The following is a description of a gene set: species: Homo sapiens HSC Human Gene Set: HE_LIM_SUN_FETAL_LUNG_C2_HSC_CELL from publication He P, Lim K, Sun D, Pett JP, Jeng Q, Polanski K, Dong Z, Bolt L, Richardson L, Mamanova L, Dabrowska M, Wilbrey-Clark A, Madissoon E, Tuong ZK, Dann E, Suo C, Goh I, Yoshida M, Nikolić MZ, Janes SM, He X, Barker RA, Teichmann SA, Marioni JC, Meyer KB, Rawlins EL (PMID 36493756), and this is the list of marker genes: ANKRD27, RIOX1 (NCBI Gene Id 79697), TBC1D31, METTL3, BOLA2-SMG1P6, LRRC70, MYLK-AS1, PKD2, TUBB4A, NREP (neuronal regeneration related protein), IL12RB2, AP1G2, KCNQ1OT1, MRPL48, CEP95, ZNF227, ZFP14, TFAP4, DYNC2LI1, LRRC23, HOPX, STARD10, TMEM68, STMN3, KPTN, WDR18, STK26, ZNF329, MAP3K7, TMEM35B, BSPRY, TRMT61B, RECQL5, ARMH1, IPO13, ZNF346, ZNF496, SQLE, ARMC6, ZNF37A, IGSF10, CNNM2, LRRC8A, ZNF420, SACS, PSMD10 (NCBI Gene Id 5716), ZNF429 (zinc finger protein 429), ZEB1, TMEM254, BCR (NCBI Gene Id 729775), POT1, DNAJC18 (DnaJ heat shock protein family (Hsp40) member C18), DDHD2, TTC4, NXPE3, RBM28, C18orf21, MLH3, DSG2, HOXB4, UNG, GLE1, ANKLE2, POLR2C, RABL2A, PRIM2, TIMM8A, TNFSF4, TRMT10C, PUS7L, GNPAT, CCAR2, GEMIN4, PKIG, OXLD1 (oxidoreductase like domain containing 1), PMS2, FBXW9, RGL4, AK6, KATNB1, MIX23, ARID5B, ZFAND2B, ING3, CERCAM, MOAP1, PRPF39, C9orf43, ARL2, USP47, SLC9B2, SVOPL, PCMTD2, ZNF574, PRKACB, NBPF1, ZNF708, ING5 (NCBI Gene Id 84289), SRP68, PHF19, SMIM8, MMUT (methylmalonyl-CoA mutase), SSBP2, TMTC4 (transmembrane O-mannosyltransferase targeting cadherins 4), TMEM63A, CAVIN1, PLA2G6, ACP6, HPS4, C1orf131, CPLANE1, PXMP2, ACTR6, WDR3, XAF1, TAPT1, RNF214, CUTC, RNF24, CNTROB, TGIF2, PTAR1, EAF2, FASTKD1, SLC27A5, TBL2, INTS8, SARS2, IPO5, TARS3, ANTXR2, MTRFR, SMYD3 (NCBI Gene Id 81838), PROM1, EIF1AY, MRPS2, CHRFAM7A, GAPT, PRR3, TMEM263, DTWD1, HIBADH, CASD1, GLI4, ECSIT, STK38, EFHC1 (NCBI Gene Id 94915), PGRMC1, MZF1, SCFD2 (sec1 family domain containing 2), CD79B, P2RX1, MMAB, PCNX4, MIR497HG, KRBOX4 (KRAB box domain containing 4), ZNF451, CERS5, ZCCHC7, PGAP2, ADK, TFPI, KCNQ5, SLC35B3, ULK4, POLD2, C12orf43, CCDC34 (NCBI Gene Id 91057), F2R, AUTS2, ABHD17B, SYTL1, ARMC8, DKC1, CFAP119, RAMP1, AGBL5, COQ4, FANCM (NCBI Gene Id 57697), CEP20, HECTD3, SLC39A3, PEX2, CIBAR1, C1RL, NSUN3, ZNF618, ZDHHC21, PRMT6, MRPL46, DDX19A, NMRAL1, TP53I3, MED20, GUF1, CENPC, UBIAD1, TOPORS, ABRAXAS2, ZC4H2, ZFP90, DYRK1B, ENTPD1-AS1, MOB2, ZNF680, KRBA2, SETMAR, ME3, RNF31, BICRAL, C16orf87, PIGM, UBL7-DT, UBFD1, DVL2, ATP8B4, SEC22C, STAP1, DLG1, ZER1, TRIM13, KIAA1586, SULT1C4, NUP35, DCAF13, GOT2, ZNF830, NBPF11, KAT6B, PAXIP1-AS2, AP3M1, PIBF1, ARHGAP22, PALS1, LRRC8B, CIAO3, ZC3H8, GORAB, ERGIC1, KANSL3, MTM1, ZW10, LINC00667, PRXL2A, PBXIP1, TGFBRAP1 (NCBI Gene Id 9392), LINC01023, MAD2L1, ITFG2-AS1 (NCBI Gene Id 647957), CASC15, OXCT1, ZFPL1, ZFP64, ZNF69, LINC01003, WDR12, ARL13B, POLR2M, EBPL, ZNF610 (NCBI Gene Id 162963), DUSP28, MYO9A, SCCPDH, SCAMP1-AS1, ADPRM, GATB, FARSB, KRR1, TIPIN, UHRF2, B3GNTL1, EXOG, ZNF506, HACD3, SAAL1, RBAK, ZNF737, MIEF1, RAB30-DT, SPINK2, IGSF8, GPANK1, ZC3HC1, MIR181A1HG, ZMYND8, TGDS, STRBP, LLPH, TEFM (transcription elongation factor, mitochondrial), DNAJC9, CCDC97, ALDH6A1, CYYR1, HNRNPA1L3, ZBTB44, FAM86C1P, PABIR2, UNC45A, HIC2, UPF3B, PIGV, COL24A1, ZFAND1, NTHL1 (NCBI Gene Id 4913), FUT8, FKBP7, GNG11, SRPK1, DOLPP1, MOV10, ZNF254, GFM2, WDR59, ZNF576, MTHFD2L, ZBED5, ZBTB8A, CD82, HELLS, HEATR1, AHDC1, PTCD3, KIZ, SRD5A3 (NCBI Gene Id 79644), ALKBH4, MEG3, ING4, SMARCAD1, TMEM184C, GFM1, MAP7D3, PPFIBP1, CEP85, TARBP1, PRELID2, LDAH, PDCD4-AS1, UHRF1, ABHD10, P2RY8, R3HDM1, METTL15, CTSF, ZNF260, LANCL1, TAMM41, EIF2D, REXO5, RAD17, BOLA1, ITFG2, EXOSC3, IGF1R, ANKRD46, ACAP1, DYNLT5, C19orf48P, LRP5L, INTS13, FHIT, BLMH, SPATS2, ARHGEF3, NPR3, TCEAL9, IFT122 (NCBI Gene Id 55764), ICA1, ZNF426, SMIM1, ANKRD36C, ANKRD26, RIDA, EARS2, ZSCAN2, ACY1, GTF3C3, RFX5, TRBC2, UBA5, DPY19L3, LRRFIP2, HOXA10, RUVBL2, SCOC, COX11, IFRD2, ATP6V0E2 (NCBI Gene Id 155066), GRWD1, BLZF1, PBX1, MAPK8, ATP23, NEDD4, PITPNA-AS1, ZNF677, ARL16, UBR5-DT, ALDH1A1, BCL2, FAM161A, OARD1, PIGU, RPP38 (ribonuclease P/MRP subunit p38), SMARCD1 (SWI/SNF related, matrix associated, actin dependent regulator of chromatin, subfamily d, member 1), PARP6, DPF2, NUTM2B-AS1, NKAPD1, HMGB3, ZNF410, JMJD4, ATXN7L1, CDCA7L, NT5C3B, SLC44A2, ZCCHC9, FHL1, PDRG1 (p53 and DNA damage regulated 1), EFL1, RAD50, MAN1B1, ALG6 (ALG6 alpha-1,3-glucosyltransferase), ZNF253, ZNF85, AGPAT4, TBCK, KLHL7 (kelch like family member 7), TRIM58, ZBTB20, ZC3H6 (NCBI Gene Id 376940), RAVER1, ARL15, TARBP2, MYCN, ODF2L, RCBTB1, NUDT11, MPI, CCNT2, PRH1, PHTF1, MAP1A, RBM48, BAMBI, ST3GAL3, SLC25A20, WASF1, PRKCQ, NNT-AS1, XXYLT1, PITPNB, GPSM2, DYNC2I1, WDR5, CXXC5, SPART, KCTD18, MRPS30, KDM1A, NQO1, CCDC171, MSH2, ANKRD28, ESAM, SMC2, RCC1, EMID1, CKB, TMEM182, ZNF875, TASP1, CSTPP1, TBCCD1, MTHFD1, KDM5B, ACYP1, NBAS, SPATA7, CCDC14 (coiled-coil domain containing 14), TXNL4B, PRMT5, PHF6, ZNF766, CDK2, MPL, SLC35E3, SCAMP1, NDUFAF7, FAM30A, DTX3, TMCC1-DT, TPGS2, CASP2, RHBDD3, MDC1 (mediator of DNA damage checkpoint 1), CD38, NME1, CCDC28B, PILRB, C15orf40, IKZF2, VAMP5, NIT2, PIGP, GGH, ZDHHC9, TOR1B, GFER, KRBOX5, MYB, HDAC7, PRKAR1B, TRAPPC2, SCML4, LINC00539, INTS9, LRBA, RBM4 (NCBI Gene Id 5936), MSMO1, EXOC6, SUPT20H, SGF29, IGFBP7, ASH1L-AS1, NCBP2, CLDN10, NAPA-AS1 (NAPA antisense RNA 1), POLR3F, GSE1, TMEM106B, ASH2L, SPIDR, GBP4, CHD1L, ANKRD36B, SLF1, HSPA13, CAND1, SYNGR1, MRPL19, INKA1, IARS1, GFI1B, TSN, CBFA2T3, UBL4A, CASP7, ASB9, NUP37, TMEM101, STN1, NT5C2, TRMT61A, SEPTIN11, MKS1, THG1L, QTRT1, DCAF16 (DDB1 and CUL4 associated factor 16), PIM1, GUCY1A1, ALG9, ZNF606, ABCB1, CXXC1, KLHL23, PRMT3, LPIN1, TMEM177, PDE7A, LAS1L, USP21, ST3GAL4, SNHG10, ERV3-1, PAPSS1, ZNF561, RRP9, LMF1, EIF3J-DT, BTN3A1, RWDD3, LRRC41 (NCBI Gene Id 89995), TSEN54, ZBTB16, JUP, ATAD1, ZNF521, CLCN3, NOLC1, C21orf58, OCIAD2, TTLL12, ZNF226, LTBP4, ZNF302, TBP, NUP155, WWOX, KIT, ZSCAN9 (zinc finger and SCAN domain containing 9), WDR54, CCDC18, TRAM2, ACTL6A, RRAGB, IMMP1L, GOLGA8B, SCML2, CCDC125, DMAC2, GMDS-DT, MEF2C-AS1, TYW3, TEX10, UBE2T, STEEP1, SIRT5, SEH1L, DUSP11, DUSP12, IQCB1, NSUN4, RNF125, ATP2C1, SETD4, SMURF2, TRAFD1, WFDC1, LYRM1, MYC, HACD1, NFATC1, RCL1, TTC27 (NCBI Gene Id 55622), IPO11, CRY1, SLC25A26, MCM3, ZNF493, GTF3C5, TAF8, HOXA7, LDAF1, DPH1, SYNE1, ZNF131, MAGED1, B3GNT2, RAC3, CDCA4, ADNP, POLR3E, LRP5, HDGFL3, ZNF771, TOP1MT, RFX3, NFRKB, CD320, MAP9, WDR46, DYTN, MZB1, ABLIM1, PTTG1, ACSM3, FAM76B, PELI2, INTS4, ROBO3, HTRA2, TMIGD2, TMCO3, TSPAN2, ACCS, HACL1, EXOSC8, MKRN2 (NCBI Gene Id 29073), VIPAS39, CHST14, ZNF639, MATK, GOLPH3L, ZNF512, ABCC1, LETMD1, EML2, ATP6V0A2, RIOK2, TMEM41A, C16orf54, PLCXD1, DPPA4, CABIN1, RSPRY1, ZNF33B, CERS6, BICD1, MAP4K2, INTS7, RBM7, SLC25A17, EXOSC7, ZNF134, H2AC25, PEX14, PIP5K1B, STRADA, DCTD, FAM216A, NAA35, ZNF268, G2E3, MRPS27, IFT57, RPAP1, HENMT1, XKR8, HIBCH, NIPAL3, NR2C1, UQCC6, STIM1, VAT1, PEX5, TTC19, ARL4D (NCBI Gene Id 379), PLAGL1, H2AC14, NAPEPLD, GFOD2, TNIK, ALDH1B1, HOMEZ, TP53I13, ECI2, NCBP2AS2, DIMT1 (NCBI Gene Id 27292), UBXN7, ORC2, METTL8 (methyltransferase 8, tRNA N3-cytidine), CD34, CASP8, GPATCH4, SLC35E2A, TTC32, INPP4B, COPG2, GALNT7, NAP1L3, PPP1R37, TMEM185B, PAPOLG, RPGR, KCNN4, BDH2, MEN1, CALCOCO1, DTD1, UBA7, EPM2AIP1, MTX2, PTP4A3, MACO1, MPHOSPH10, CD7, GSTM3, CDK17, PDCD11, ACSS1, HDAC8, KEAP1, ABRAXAS1, AASDH, RGS3, LAPTM4B, MFSD14A, MFAP1, CLEC11A, MEX3A, ZNF439, PEAR1, CDT1, KIFAP3, CHRNB1, YIPF2, SLC35B2, NR1H3 (nuclear receptor subfamily 1 group H member 3), DLK1, FASTKD2, GATA2, GMPS, MDM1, GPR89A, TIA1, RMND1, FAM222B, PNMA1, ARMCX1, EPS15L1 (epidermal growth factor receptor pathway substrate 15 like 1), BTBD3, HCG11, MCM7, REPS1, KLHL6, ATG4D, GLMN, ERCC3, F2RL1, ZMYM1, GATC (glutamyl-tRNA amidotransferase subunit C), TMA16, GAR1, SP2, CBX5, KICS2, MTR, PIAS4, TBC1D25, RNF8, FASTKD5, LRRC27, ISY1, CUL4A, TBC1D23, CCNJ, HDDC2, PAICS, MAPKAPK5-AS1, LRRC61, ITGB3BP, MCRS1 (microspherule protein 1), H2BC11, BRF2, PIGB, NBN, DNMT3B, SUPT3H, PSPH, ZNF75A, CENPT, MINPP1, ZNF195, CIAPIN1, MRM3, CAVIN2, TBC1D10C, MFGE8, NOL11, METTL17, TMEM9, SPMIP4, HMG20A, GART, HSH2D, MSI2, C2orf69, DEPTOR, IFT22, NUCB2, ZNF91, TTN-AS1, C12orf76, EPB41L4A-AS1, ZSCAN21, PHC1, IGLL1, SUGP1, BMP1, MCTP2, ZNF738, MTMR2, GPN1, BNIP1, PM20D2, EPDR1, DTNB, LZTS2, ZNF711, PDLIM1, GBP2, ACOT2, STAMBP, ACAT2, DNAL4, PES1, SKAP1, CASP3, SORD, PTGDR2, IMMP2L, PLA2G12A, SELENOI, DCTPP1, CD244, CCDC152, ZSCAN18, MRPS9, GBP3, ATP2A3, NUP107, CRCP, COIL, PRR7, TADA1, SOCS2, DHRS4-AS1, NELFA, RHOBTB3, MECOM, LINC02573, WDR49, SNCA, DBN1, FBXL4, CYFIP2, NEDD1, IFI27L1, ZC3H14, MACROD1, HDHD3, MRPS22, HOXA9, METAP1D, LONRF1, SLC41A3, FAIM, TMEM185A, CDCA7 (NCBI Gene Id 83879), PRSS57, ATPSCKMT, ANAPC10, CTSW, CNKSR3, CFAP68, URI1, RPAP2, PDIK1L, DUS2, NOL8, KLHL12, NOA1, RAB34, RRP8, COX15, IFT172, PGM2L1, POLM, GMPR, LIG3, RCC1L, COQ8A, EEF1AKMT2, MRPS14, ZNF529, C1QTNF4, DLST, CCDC71, SLC12A2-DT, ZNHIT6, SRBD1, HOXB2, RIMKLB, NOMO1, MAP7 (microtubule associated protein 7), EDEM2, PFAS, MIR181A2HG, DSTYK, FPGS, APP (amyloid beta precursor protein), PFKM, PFKP, ZNF281, METTL14, MRPL50, EVA1B, IDNK, CCDC127, SMIM27, SPTBN1, HTR1F, TRIM24, POLR3D, ALKBH2, BSCL2, APTR, RAD51C, WARS2, ACAA2, AFAP1L2, BIN3, ORAI2 (ORAI calcium release-activated calcium modulator 2), TTC31 (NCBI Gene Id 64427), C11orf21, SRSF8, DIPK1B, PXN-AS1, ZNF667-AS1, MRPL1, PAK1IP1, EDC3, ERLIN1, IMPA1, MAN2A2, TMEM216, NIFK-AS1, TTC5 (tetratricopeptide repeat domain 5), CEP41, ATG10, DGKE, SLC25A38, TMEM245, NFYA, DZIP3, ZNRF1, CDADC1, IP6K2, XPOT, CALCRL, LMBR1, GSTM2, PPM1D, ANKRD36, ADAT2, DAPK1, MEIS1, GLIDR, SETD9, GPR89B, ZNF28, PRUNE1 (NCBI Gene Id 91961, prune exopolyphosphatase 1), RCN2, HAT1, TSPAN13, OMA1, ZNF397, LZTFL1, SMAD1, ATIC, ANGPT1, SYNGAP1, STRIP1, MLST8, ZMYM4, YAE1 (NCBI Gene Id 57002), COA1, CHST13, PTPN7, CD200, MLC1, MFAP4, JAM3, AK3, OSGEPL1, CEBPZOS (CEBPZ opposite strand), ZNF74, CD109, PIGBOS1, CENPH, TRIM52, CGRRF1, ITGA6, MRE11, CLSTN3, ANAPC1, LMNB1, GUCY1B1, BCAS4, FIRRE, NTPCR, ZNF627, KNOP1, GNPNAT1, MPHOSPH9, CCDC25, DGLUCY, ITGA5, SMARCAL1, STX17, ACOT13, ZNF668, RAB37, ZNF326, CLP1, HLTF, MCM2, PMM2, TIMM9, TEC, PSMG4, DNMT3A, NLE1, CNOT10, SHF, PRPS1, LEMD3, ZKSCAN1, MYO18A, ATXN7L3B (NCBI Gene Id 552889), POGLUT1, CEP83, CPA3, SMAD5, ARB2A, CCNB1IP1, MRPL45, SLC25A29, MRPL42, TCAF1, ICE2, SDE2, IQSEC3-AS2, ZNF736, CA8, PPAT, BEND5, CEP290, NT5C3A, POC1B, TMEM18, COQ9, CHST11, ZNF444, RPP40, YARS2, L3HYPDH, TRH, TSEN15, MOK, B4GALT6 (beta-1,4-galactosyltransferase 6), CLDN15, KLHDC2, ABCB7, FAHD2B, BAALC (BAALC binder of MAP3K1 and KLF4), CPT2, HMGA2, POLD1, TMEM260, TSTD1, LSG1, FGF16, ERG28, PIK3C3, GTPBP3, CRIPT, MIR4458HG, CETN3, PAM, ZMYND11, TOX, CEP192, ELP6, PHLPP1, STK16, CHEK2, NVL (NCBI Gene Id 4931), SLC9A7, GPHN, ODF2, PLCB1, FRA10AC1, TFB2M, PLPP1 (NCBI Gene Id 94702), PDCL, NDUFAF6, TRNT1, PTGER2, HPGD, TBC1D22B, TM7SF3, SATB1, GABPA, EBP, SLC38A5, KLHL20, COG6, PNPT1, MRPS18A, TRUB2, COQ8B, SLC17A9, TMEM11, CKAP2, MARK4, RCE1, SHPRH, VRK1, TMEM43, GMDS, PYCR1, OGFOD1, SUPV3L1, RBPMS, CRYGD, ZFYVE27, BRD8, NGDN, MTG1 (NCBI Gene Id 92170), PLAG1, RABGAP1, CRYZL1, HARS1, SERF1A, CHST12, HEMGN, CSGALNACT1, MCM3AP-AS1, AAR2, ISOC1, HAUS1, SVIP, CMBL, ARSD, TYMS, MAST4, DMAC2L, IGF2BP2, RCCD1, ARSK, AP4M1, IL27RA, POLL, TMEM69, CNPY2, MAGEH1, MED17, YDJC, HYAL3, MLLT3, FSTL1, TESMIN, LRRC42, RUSF1, SMN2, SERF1B, EMC2, PRKCH, NUFIP1 (NCBI Gene Id 26747), NOC3L, ALDH18A1, NFE2, PEX6, ADCY3, TSTD2 (NCBI Gene Id 158427), NAE1, TMEM87A, PPIE, NOG, RBM41, MACIR, KBTBD4, MSRB3, FANCF, MMRN1, GRAP, TSC22D1, YARS1, HSD17B8, METTL1, ELP3, HUS1, VILL, LYRM9, USP14, SLC43A1, EXOSC2, FAM219B, SHQ1, CCDC102A, RNF220, HAUS3, PRIM1 (NCBI Gene Id 5557), FUNDC1, CYTL1, RAB3IP, DHCR7-DT, ESCO1, ZNF84, RRP15, SPAG16, MIB1, KLF12, ERG, MRPL10, KRIT1, ITM2A, PDE4D, MRTO4, KHDC4, LINC02210-CRHR1, TESPA1 (NCBI Gene Id 9840), ZFYVE1, PINLYP, RNASEH1-DT, LINC03052, ACBD6, CYP2R1, ETFRF1, BDH1, OBI1, HYAL2, STAT5B, PLPP5, SGO2, TCEANC2, NGLY1, SNHG30, NUDT17, ZNF664, B3GALNT1, LIAS, TIE1, ULK3 (unc-51 like kinase 3), POLR2D, KLRG1, FAR2, CEP57L1, GSTM1, EZH2, NIPSNAP1, ISYNA1, AFMID, NOP2 (NCBI Gene Id 4839), SERPINE2, HDAC6, DUSP10, SCRN2, FANCL, IFTAP, SLC30A9, ZNF7, RBM34, C14orf93, PAAF1, CDKN2AIPNL, PIGO, CPXM1, SUCLA2, DNAAF2, PTER, HEXD (NCBI Gene Id 284004), PPP1R8, GATA2-AS1, AAMDC, USP20, GCFC2, RUVBL1, ZNF717, NUP54, KIF9, CBX2 (chromobox 2), SORL1, ABL2, MPO, FAHD2A, CMSS1, NDUFAF1, DDX1, ZNF691, GPR146, NME6, ADGRG1, ZNF121, MFAP2, AUH, TPRA1, NR6A1, RAD18, P4HTM, TFB1M, CCNB1 (NCBI Gene Id 891), GTF3C2, DUS3L, CSTF3, POLG2, CDC23, TRIM56, FADS2, ZBTB45, PTPRCAP, IL1RAP, RNF144A, EXD3, JPX, GPX7, DCAF6, TNPO2, DNAH14, LXN, REC8, UBA6-DT, NMD3, TPCN2, PSKH1, POLI, PEX10, UNC13D, TMEM163, SIRT3, RETREG3, SAMD13, SPTAN1, TMEM38B, CPT1A, RXYLT1, CROCC, RCN1, MRM1 (NCBI Gene Id 79922), PCYT2, SPOCK2 (SPARC (osteonectin), cwcv and kazal like domains proteoglycan 2), FAM117A (NCBI Gene Id 81558), CFAP298, POLR1F, CFAP36, CENPF, LINC00623, C20orf96, TRMT13, NHLRC3, LDOC1, METTL2A, METAP1 (methionyl aminopeptidase 1), ZNF141, REXO2, USP42, AEBP1, PLEKHA5, NR2C2AP, BEX3, WDR75, RSAD1, PAM16, MUTYH (NCBI Gene Id 4595), MRPL49, CDK6 (NCBI Gene Id 1021), TDP2, SLC48A1, TSPAN32, PDCD7, GNA12, TSPYL4, MBD5, THOC3, SPIN1, RHEX, TXLNG, CREB3L4, LRRC8D, ADA, IRF4, PAK4, MAP2K5, MZT1, SPRY1, ERAL1, UTP4, SCMH1, GCNT1, PYGO2, USP11, ASF1A, SPIN2B, MANBAL, BMS1, MECR, ZNF692, SLC37A1, ELAC2, KMT2A, POLR1C, TUBB6, NME7 (NME/NM23 family member 7), NUDCD1, RGP1, CD69, DCUN1D5, ANAPC7, TUBGCP4, CSTF2T, ZNF266, RNASEH2A (NCBI Gene Id 10535), PCCB, PREP, CMTM8, ZNF445, ZNF566, AGL, MYL6B, MDK, SLC45A3, TAF2, LYRM7, WRNIP1, ELK1, RALGPS2, NUDT2, SEC22B, LINC00665, DFFA, MTNAP1 (mitochondrial nucleoid associated protein 1), TMEM106C, RPTOR, PXDN, TEX30, ERCC8, DPH5, FLNB, YEATS4, METTL18, CENPK, GMCL1, MED21, EIF4EBP3, PODXL2, SCARF1, NAA80, SFXN1, PPWD1, WDR83, CDKN2AIP, CCDC122, TOGARAM1, TRO, RHOH, DPH7, CASP6, SNHG19, DDX55 (DEAD-box helicase 55), CENPU, EXTL2, AP4B1, NOB1, NSMAF, TRIP6 (NCBI Gene Id 96624), GSKIP, ANKS3, RHOBTB1, TMEM220, DMAP1, MRPL2, IGF2BP1, BEX2, ELP2, DPH6, CTPS2, RBM12B, TRIM4, CEP97, FAM50B, ETAA1, NUBPL, ABT1, P3H1, SWSAP1, CCND2, GNAI1, ANKMY2, PHGDH, MIS18A, ELOA-AS1, TMEM220-AS1, TIMP3, ZKSCAN4, HCG18, HSF2, WDR48, SLC16A1, TMEM135, MTERF3, RPRD1A, PRIMPOL, SMIM24 (NCBI Gene Id 284422), ICAM2, GCDH, RPUSD4, FBXO38, BCL7A, TAB1, SLC22A16, MEST, WDR43 (NCBI Gene Id 23160, WD repeat domain 43), CSPP1, IL18, TRANK1, PIAS3, CRNDE, SPATC1L, NARS2, SLC39A8, MRPL32, CNST, FAM200A, CEP68, SFXN4, GABPB1, FMC1, ARHGEF9, NDN, TFDP2, RBM19, ALG8, WDSUB1, B9D2, ERICH6-AS1, LINC00662, CFAP20, RP9, CTPS1, DCAF17, GSTZ1, KCTD3, PTK2B, MEX3B, FADS1, POGLUT2, DDX50, MED19, CSTF1, FHIP2A, MMS19, NIP7, RABEPK, PMS1, MTRF1L, VEZT, RARS1, GABPB1-AS1, SNAPC3, RFC3, RRP1B (ribosomal RNA processing 1B), RNFT1, PALS2, ERAP1, S1PR4, MTHFSD